Given this list of marker genes Psmd14, Ranbp2, Pgap2, Lyn, Rftn1, Herc6 (hect domain and RLD 6), Gbp8, Oas1a, Mapre1, Pa2g4, Btg1, Tmed5, Wdr1 (NCBI Gene Id 28041), Ddx24, Psmb10, Tmem106a, Ccr7, Nup98, Sdc4, Grb2, Snn (stannin), Rcl1, Cxcl16, Mreg, Diaph1, Clic4, Cxcl10, Nfkbia, Car13, Timd4, Hyou1, Ehbp1l1, Riok3, Cyria, Sbno2, Actr2 (NCBI Gene Id 66713), Psmc5, Msmo1, Dnajc21, Nrp2, Slfn1, Edf1, Cfl1, Kmo, Nfkb2, Psma5 (proteasome subunit alpha 5), Gbp4, Cish, Tnip3, Trim30a, Cnn3, Ctsz, Gatm, Gbp7, Ube2l6, Vdr, Rpn1, Jak2, Oas3, Cdkn1a, Ifi205, Malt1 (NCBI Gene Id 240354), Ascc3, Arhgap31, Itgb1, Hsp90ab1, Ehd1, Flnb, Il7r, Atp1a1, Fgl2, Cd274, Nipal1, Lrrc8c, Tap2, Ldlr, Sod2, Sp110, Nckap1l, Rnf213 (NCBI Gene Id 672511), Spin1, Cycs, Stat3, Dtx3l, Ccl22, Prdm1, Mvp, Atf5, Car2, Pdia3, Snap23, Emd, Stat5a, Tubb6, Mllt6, Cacnb3, Cyp51 (NCBI Gene Id 13121), Myl6, Eif5, Cflar, Psme2, Rap2a, Casp4, Klf7 (Kruppel-like transcription factor 7 (ubiquitous)), Trim30d, Tuba1c, Cyrib, Mon1b, Scimp, Tmem123, Timm17a, Phf11d, Parp14, Nectin2, Tubb4b, Casp8, Tap1, Selenok, Tmbim6, Ifi47, Sinhcaf, Necap2, Actr3 (ARP3 actin-related protein 3), S100a4, Nampt, Dusp5, Psme1, Anxa7, Dok1, Ndufs4, Ifitm3, Dok2, Fdps, Srsf7, Pacsin2, Hnrnpa3, Isg15, Canx, Mif4gd, Nras, Gpr132, Bcl2a1b, Fdft1, Sppl2a, Cxcl9, Spred1, Bcl2a1d, Kdm6b, Hif1a, Eif1, Rab11a, Rbm3, Relb (avian reticuloendotheliosis viral (v-rel) oncogene related B), Psma4, Pdia6, Myadm, Psmb7, Traf1, Tpm3, Ewsr1, Pfn1, Rab7, Lcp1, Pdcd1lg2, Castor2, Ggct, Ly6a, Nr4a3, Nup88, Tmem167, Hax1 (NCBI Gene Id 23897), Tuba1a, Myo1e, Fabp5, Etv6, Hspd1, Crabp2, Il4i1, Pdcl3, Eif5a, AA467197, Rnh1, Csrp1, Pdcd10 (NCBI Gene Id 80414), Slc30a4, Ifi204, Tapbpl, Vasp, Hsp90b1, Tbc1d1, Parp12, Fyn, Tarm1, Ppp4r2, Bcl2l14, Mbd2 (methyl-CpG binding domain protein 2), Rab8b, Sec61g, Psma3, Pdcd6ip, Cyp7b1 (NCBI Gene Id 99900), Fnbp1l, Ly75, Hnrnpk, Il4ra, Cd86, Msn, Ssr2, Zdhhc6, Gabarap, Ywhae, Golgb1, Ywhaq, Cox17, Ngfr, Plet1, Runx3, Rmdn3, Tspan13, Rigi, Rel, Calr, Ak2, Icam1, Atp11a, Manf, Mrpl20, Gnai3, Batf3, Xaf1, Elob, Cdh1, Mndal, Sra1, Ifitm1, Lfng, Zbp1, Rala, Dcun1d5, Srsf3, Prnp, Cnn2, Cd83, Tmed7, Tgm2, Spint1, Mt1, Gadd45b, Ifi207, Zcchc17, Slamf1, Ffar2, Bcl3, Rpain, Pik3r1, Pgs1, Igtp, Nmi, Prps1, Srsf2, Ccl17, Serpina3g, Spi1, Pcyt2, Sh3bgrl (NCBI Gene Id 68890), Adam8, Phf11b (PHD finger protein 11B), Atp6v0a1, Ankrd33b, Iigp1, Creld2, Ilrun, Gnb1, Ccnd2, BC031181, Tpm4, Gbp5, Acsl5, Rbm8a, Gbp2, Ifitm2, Lilrb4b, Kdr, Pfkp, Gpbp1, Chchd2, Pnp, Slfn2, Arpc2, Xbp1, Flot1, Bhlhe40, Selenos, Timp1, Socs2, Anxa3, Birc3, Coro2a, Ass1, Arpc4, Psmd12, Erh, Kdm5c, Arpc5, Dusp2, Glrx, Uap1, Glipr2, Chd7, Acvr2a, Marcksl1, Fbxo11, Tbcb, Myd88, Arap2, Slc33a1, Nfat5, Col27a1, Eloc, Basp1, Hspa8, Gch1, Tes, Bcl2a1a, Prpf31, Lsm12, Kif1a, Rap2b (NCBI Gene Id 99478), Atxn2l, E2f4, Psmb9, Socs1, Etf1, Irf5, Csf2rb, Id2, Orai1, Hmgcs1 (3-hydroxy-3-methylglutaryl-Coenzyme A synthase 1), Mmp25, Lap3, Olfm1, Isg20, Prkcd, Hsp90aa1, Dnajb11, Eif3c, Slc35b1, Mrpl52, Stat1, Zfp296, Irgm1, Map3k14, Irf1, Edem1, Ube2n, Syngr2, Arl1 (ADP-ribosylation factor-like 1), Trafd1, Pkib, Alyref, Ndufa3, Stx11, Rgs1, Snrpg, Il21r, Casp1, Myl12a, Ptger4, Vti1a, Jtb, Aebp2 (AE binding protein 2), Dynll1, Eif1a, Irgm2, Ppa1, Polr3c, Prdx1, Snx3, Arhgdia, Rab21, Clec2d, Sar1a, Aamp, Ifi35, Sfpq, Ms4a4c, Chmp4b, Pcgf5, Gpr183, Ms4a6d, Plpbp, Pmvk, Apobec3, Marcks, Nudt17, Ube2i, Hpcal1, Tle3, Gfra2, Cfp (complement factor properdin), Hnrnpc, Sel1l, Exosc3, Idi1, Calm1, Cd164, Cct3, Clec4n, Wfdc17, Ctbp1, Casz1, Slc3a2, Gpr35, Eif4e, Tmem39a (NCBI Gene Id 67846), Gbp9, Uck2, Vim, Eif6, Fscn1, Ube2j2, Swap70 (SWA-70 protein), Nr1h3, Dram1, Plxna1, Slfn5, Mthfs, Hmgcr, Etv3, Txnrd1, Ifi211, Myo1g, Psmb5, Litaf, Il1rn, Irf7, Pik3r5, Jaml, Cd40, Zfp366, Htr7, Gimap1, Tspo, Pno1, Srgn, Il1b, Oasl2 (2'-5' oligoadenylate synthetase-like 2), Socs3, Mrpl11, Ptpn1, Atp5mk, Efhd2, Rras2, Uqcrq, Abracl, Pogk, Cd300lf, Dnajb9, Hspa5, Bud23, Psma6, Psmd7, Tagln2, Ost4, Lrrk1, Tuba1b, Gadd45g, Eif4a1, Birc2, Psma2, Plscr1, Eif2ak2, Brix1, Nlrc5, Ramp3, S100a11, Snx2, Vcp, Acot7, Actg1, Adora2a, Psmd11, Anxa2, Tmem131, Cd53, here is a description of the gene set: Mouse Gene Set: CUI_CDC2_IL36A_RESPONSE_UP Cytokines mediate cell-cell communication in the immune system and represent important therapeutic targets. A myriad of studies have highlighted their central role in immune function, yet we lack a global view of the cellular responses of each immune cell type to each cytokine. To address this gap, the authors created the Immune Dictionary, a compendium of single-cell transcriptomic profiles of more than 17 immune cell types in response to each of 86 cytokines (>1,400 cytokine-cell type combinations) in mouse lymph nodes in vivo. A cytokine-centric view of the dictionary revealed that most cytokines induce highly cell-type-specific responses. For example, the inflammatory cytokine interleukin-1β induces distinct gene programmes in almost every cell type. A cell-type-centric view of the dictionary identified more than 66 cytokine-driven cellular polarization states across immune cell types, including previously uncharacterized states such as an interleukin-18-induced polyfunctional natural killer cell state. Genes positively differentially expressed in cell type: cDC2 (conventional dendritic cell type 2) upon treatment with cytokine: IL-36α in mouse lymph nodes in vivo. from publication Cui A, Huang T, Li S, Ma A, Pérez JL, Sander C, Keskin DB, Wu CJ, Fraenkel E, Hacohen N (PMID 38057668) studied in species Mus musculus